Given this list of marker genes Slc6a3, Wnt5a, Opn3, Npy, Aldh2, Rnf180, Tyr, Cyp2e1, Tpo, Rnls, Slco4a1, a, Mtpn, Zeb2, Sult1a1, Sult2a8, Atp7a, Snca, Star, Tyrp1, Insm1, Comt, Tg, Th, Tph2, Pnkd, Mfsd12, Slco1c1, Hdc, Dio1, Slc16a10, Sult2a1, Crhr2, Slc5a5, Gnat2, Duoxa1, Sult2a5, Cdh3, Duoxa2, Gipc1, Dct, Itgam, Slc7a11, Hand2, Htr1a, Sult2a4, Gata3, Sult2a6, Ndufs4, Tomt, Duox2 (NCBI Gene Id 279020), Ctsb, Cited1, Dio2, Maoa, Ednra, Grin2a, Moxd1, Sncb, Slc45a2, Rtl4, Agtr1a, Fah, Pmel, Drd4, Spr, Oca2, Mdga1, Ddc, Bcl2, Sncaip, Ddt, Gch1, Vps35, Cga (glycoprotein hormones, alpha subunit), Epas1, Mc1r, Sult2a7, Dao, Akr1b1, Sult1d1, Prkn, Cyp2d22 (NCBI Gene Id 56448), Pax8, Dio3, Dbh, Slc16a2, Tph1, Hpn, Slc1a1, Rapgef2, Ly6e, Rab38, Aoc2, Slitrk1, Agtr2, Vhl, Npr1, Park7, Pde1b, Tgfb2, Sult2a2, Sult2a3, Pnmt, Abat, Iyd, Gcnt4, Tacr3, Med1, Kl, Drd2, Kcnj6, Gpr37, Htr2c, Chrnb2, Hprt1, Cyp1a1 (NCBI Gene Id 13076), Crym, Atp2b2, Drd1, Reln, Moxd2, Ctsl, Foxe1, Nr4a2, Ctns, Cpq, Trpc1, Ctsk, Myo5a, Slc24a5, Maob, Slc26a7, Sult1b1 (NCBI Gene Id 56362), Btbd9, Appl1, Fev, here is a description of the gene set: The chemical reactions and pathways involving a phenol, any compound containing one or more hydroxyl groups directly attached to an aromatic carbon ring. studied in species Mus musculus Mouse Gene Set: GOBP_PHENOL_CONTAINING_COMPOUND_METABOLIC_PROCESS